Given this list of marker genes NR1H4, PDK3, AKR1C2, LDLR, MIR92A1 (microRNA 92a-1), CREB1 (cAMP responsive element binding protein 1), KCNK10, DGAT2, ASS1, PLCB1, IRS1, CAV3, LPL, CD4, UCP1, KCNK2, FFAR3, ZC3H12A, CCNB1, ZNF683 (NCBI Gene Id 257101), PID1, E2F1, HES1, EDN1, CPT1A, AKR1C4, FFAR2, PRKCD, KCNK4, AKR1C1, JUND, SMARCD1, HMGCS2, CDK4, ID3, CPS1, SREBF1, CLDN1, OR51E2, PDK4, AKR1C3, here is a description of the gene set: studied in species Homo sapiens Human Gene Set: GOBP_CELLULAR_RESPONSE_TO_FATTY_ACID Any process that results in a change in state or activity of a cell (in terms of movement, secretion, enzyme production, gene expression, etc.) as a result of a fatty acid stimulus.